The following is a description of a gene set: Mouse Gene Set: GOBP_EMBRYONIC_ORGAN_DEVELOPMENT species: Mus musculus Development, taking place during the embryonic phase, of a tissue or tissues that work together to perform a specific function or functions. Development pertains to the process whose specific outcome is the progression of a structure over time, from its formation to the mature structure. Organs are commonly observed as visibly distinct structures, but may also exist as loosely associated clusters of cells that work together to perform a specific function or functions., and this is the list of marker genes: Phlda2, Ttc39c, Grhl3, Flvcr1, Hoxa3, Ccn1 (NCBI Gene Id 99596), Pax8, Runx1, Palb2, Dlx5, Hand1, Ryr2, Wnt5a, Lrp6, Gja1, Six1, Tmed2, En2, Tmem94, Otx2, Slc8a1, Rtl1, Hoxa11, Hoxc11, Ankrd24, Noto, Gas1, Plxna4, Zic3, Lmo2, Ihh, Sufu (SUFU negative regulator of hedgehog signaling), Mef2c, Ift57, Rarb, Dlx6, Ercc2, Pdgfrb, Ush1g, Efna1, Zfp568, Irx5, Neurog1, Itga8, Hoxd4, Asb2, Atoh1, Nodal, Trp53, Spint1, Med12, Ccdc39, Pbx4, Kcnq1, Hif1a, Lbx1, Eng, Plg, Gjb5, Tfap2a, Foxf1, Gcm1, Ggnbp2, Mir449b, Dlx1as, Sparc, Cfc1, Hoxa1, Mafb, Myo7a, Rpl10-ps3, Pdgfra (platelet derived growth factor receptor, alpha polypeptide), Chd7, Pkdcc, Enpp1, Pcdh15, Kdm1a (NCBI Gene Id 99982), Ppp1r13l, Krt8, Frs2, Elf5, Gata4, Csf2, Strc, Fendrr, Ptk7, Hlx, Rbpj, Ccdc40, Ift122, Hoxd11, Alx1, Itgav, Llgl2, Arid2, Alx4, Pdgfb, Neurod1, 2610005L07Rik, Eya4, E2f7, Cdc42, Invs, Crxos, Stil, Hey1, Syde1, Slc39a3, Mdfi, Mfap2, Ovol2, Tbx1, Il3, Shox2, Lrig3, Eya1, Dync2i1, Edn1, Prkra, Chrd, Aplnr, Kdm6a, Slitrk6, Pds5a, Cluap1, Cdx4, Sp2, Mfsd2a, Mapk3, Stra6, Epas1, Gab1, E2f8, Ercc3, Sp3, Hipk1, Prox1, Akt1, Nectin3, Hes1, Kdm2b, Myc, Greb1l, Hoxc4, Hoxa9, Cited1, Lhx1, Vash2, Plac1, Gli3, Eif4a3, Fzd5, Sod1, Utp25, Mir34c, Senp2 (SUMO/sentrin specific peptidase 2), Eomes, Stox1, Hoxa4, Six4, Foxe1, Ncoa3, Pitx2, Tead2, Insig2, Ephb2, Mical2, Hnf1b, Prickle2, Epn1, Psen1 (NCBI Gene Id 19164), Tcap, Chst11, Dlg1, Kdm2a, Tcf21, Ctnnb1 (catenin beta 1), Atp8a2, Sox11, Pax2, Cdc40, Fgf10, Eif4a3l1, Gbx2, Klf1, Ncoa1, Mks1, Sp1, Cep290, Myo15a, Setdb2, Slc39a1, Epha2, Sall1, Cdk20, Dvl1, Hoxd9, Foxc1, Rbbp6, Wdpcp, Wnt3a, Smo, Gja5, Grxcr2 (NCBI Gene Id 332309), Th, Dnajb6, Id2, Notch1, Atf4 (activating transcription factor 4), Tpo, Vcam1, Zfat, Tcf7, Folr1, Triobp, Ednra, Taf10, Krt19 (keratin 19), Mbd2, Epn2, Shh, Hipk2, Bmi1, Aldh1a1, Foxd3, Foxl2, Ptch1, Fbxw8, Wdr48, Tifab, Gata2, Frzb, Cdh23, Pbx2, Bloc1s5, Nipbl, Rara, Rbpms2, Otx1, Naglu, Thoc5, Foxf2, Tulp3, Rpl38, Nphp3, Synb, Hey2, Lrig1, Bmpr1a (bone morphogenetic protein receptor, type 1A), Pkd2, Hoxb6, Crb2, Tmie, Osr2, Nr2f2, Hoxa5, En1, Megf8 (NCBI Gene Id 269878), Abr, Plcd3, Sox2, Vash1, Fgf9, Mib1, Prrx1, Tead4, Nog, Fgfr2, Slc44a4, Vps52, Syna, Fgf8, Rpl10, Pdzd7, Ripor2, Gdf3, Bmp4, Nectin1, Gsc, Hoxd3, Vegfa, Foxi1, Plcd1, Zfpm1, Dscaml1, Esrrb, Ndst1, Dvl3, Wdr19, Stk3, Nrk, Tgfb2, Hs6st1, Cited2, Pax5, Prickle1, Fbn2, Tfeb, Tnrc6c, Tshr, Birc6, Nr4a3, Ccdc134 (NCBI Gene Id 76457), Hoxb1, A2m, Zfpm2, Uty, Kmt2a, Tbx2, Bmp5, Ttpa, Smad3, Vangl2, Il10, Wnt7b, Dnaaf1, Cdx2, Ncoa6, Hectd1, Kat6a, Ntn1, Satb2, Tbx4, Hesx1, Gnas, Tgfbr1, Tecta, Ift172, Ift52, Hoxb5, Map2k1, Cntnap2, Efemp1, Vax2, Xist, Sobp, Socs3, Nkx2-6, Mir127, Clrn1, Six2, Gata3, Clrn2, Phactr4, Grhl2, Tex19.1, Celsr1, Mir34b, Pls1, Mir96, Hpn, Bptf (bromodomain PHD finger transcription factor), Junb, Zeb1, Rbp4, Cebpa, Bmp7, Clic5, Pbx3, Myb, Foxc2, Mmp14, Col11a1, Wnt9b, Insig1, Srf, Kcnq4, Bcr, Hoxd10, Foxh1, Hoxb8, Myo6 (myosin VI), Tead3, Fgf3, Tgfb3, Tbx3, Msx1, Egln1, Dll1, Twist2, Col2a1, Med1, Plk4, Hoxb9, Cts7, Pdgfa, Grxcr1, Gdnf, Kitl, Ascl2, Ada, Rac1, Ptprq, Mrtfb, Smad2, Arl13b, Ush1c, Lif (NCBI Gene Id 16878), Hmx3, Mmp16, Hsf1, Wnt1, Ccdc103, Sox18, Nherf1, Sec24b, Tcf7l2, Aldh1a3, Atp2b2, Pou4f3, Yap1, Mapk1, Wnt2, Myo3a, Myo3b (NCBI Gene Id 635238), Pcdh12, Nkx2-5, St14, Six3, Fzd6, Dvl2, Gata1, Hmx2, Sap130, Tgfbr2, Stk4, Mir449a, Hhex, Alx3, Pcdha9, Hoxb2, Cebpb, Asxl2, Esx1, Tra2b, Prdm1, Acvr1, Cryaa, Tbx15, Pcsk5, T, Tbc1d23, Prrx2, Pole, Hoxa2, C2cd3, Gjb6, Nkx3-2, Runx2, Mycn, Sox15, Mir449c, Smarca4, Tprn (taperin), Hyal1, Traf3ip1, Axin1, Spint2, Gli2, Zfp36l1, Aldh1a2, Ppil1, Erf, Hscb (NCBI Gene Id 231610), Egfr, Tnf, Pbx1 (NCBI Gene Id 98516), Mfap5, Notch2, Gli1, Fgfr1, Cc2d2a, Mbd3, Nckap1, Chrna9, Tal1, Rnf112, Snai1, Adm, Tubb2b, Apela, Fzd3, Kdr, Hoxb3, Hspg2, Cthrc1, Cimap3, Hoxb4, Foxn4, Tshz1, Lef1 (lymphoid enhancer binding factor 1), Arnt, Rarg (NCBI Gene Id 19411), Wnt11, Tbx20, Cts8, Wnt9a, Scrib (scribbled planar cell polarity), Zic1, Tead1, Ece1, Dlx2, Rest, Rnf207, Trim28, Rdh10, Pcgf2, Atp6v1b1, Ercc1, Ext1, Syf2, Fzd2, Pax6, Grb2, Flt3l, Mesp1, Tgfb1, Cobl (cordon-bleu WH2 repeat), Hand2, Myf5, Eif4a3l2, Kif3a, Nsdhl, Igf2, Arid1a, Id3, Itga4, Chrna10, Fuz, Pkd1, Otop1, Fbn1, Pcnt, Gfi1, Men1, Osr1, Sh2b3, Rad23b, Hoxa7, Kit (KIT proto-oncogene receptor tyrosine kinase), T2 (brachyury 2, NCBI Gene Id 21331), Ldb1 (LIM domain binding 1), Whrn, Hoxc9, Nes, Rspo3, Hsd17b7, Cdkn1c, Lhfpl5, Hoxb7, Setd2, Ift140, Tbx18, Sox9, Ror2, Pou3f4, Sox17, Rarres2, Nfe2, Ppp1r35, Spry2, Foxg1, Twist1, Mthfd1l, Ttbk2